Given this list of marker genes G6PC2, AMOTL2, NGFR, ABCD1, NXPH3, CMTR1, CCDC3, HOXC8, KATNAL2, ATG16L1 (NCBI Gene Id 81560), DNMT3B, TTYH3, GIT1, NFASC, RPAP3, LHX6, GATAD2B, CRLF2, INTS6, H2AB1, SPINT3, ERN2, BCL2L1 (NCBI Gene Id 598), NOVA2, ABCC6, LDB3, CYP26B1, MMP24, IGFL3, RSPO4, MYO18A, ELAVL4, BCL7B, IQSEC2, SLC9A1, C5orf15, HCN2, TXK, RIMOC1, C6orf141, MECP2, SEPTIN6 (NCBI Gene Id 23157), TADA3, MPL, CPLX2, SKI, FOXP4, AVPR1A, SYT7 (NCBI Gene Id 9066), TXNRD1, SPATA31D4, PDLIM3, SHISAL1, ADORA3, NSL1, ZSWIM4, SERTAD2, CAPN15, NECTIN1, DTX3, MTHFSD, P2RY4, KCNAB2, IDH3B, LAMC1, PPP2R1A, SLC22A7, PRELP, SEMA4G, MSN, ACSF2, ANKRD13B, BCL7A, URM1, TTC9, CASK, CCDC97, PLEKHM3, CASTOR2, NTSR1, DERL1 (NCBI Gene Id 79139), GARS1, ZC3H7B, STAC2, CNDP1, CENPI, FIBCD1, CBFA2T2, PAX5, BCORL1, SLC6A17, SLC7A8, SEMA6A, NUAK2, GCM1, STX1B, LSAMP, DDA1, PTPDC1, MSI1, MAP3K9, OPA3, VAMP2, TIE1, NFIC, TCF12, ARL5B, ATG14, NACC1, IGF2, here is a description of the gene set: Human Gene Set: MIR4472 Genes predicted to be targets of miRBase v22 microRNA hsa-miR-4472 in miRDB v6.0 with MirTarget v4 prediction scores > 80 (high confidence targets). from publication Chen Y, Wang X (PMID 31504780) studied in species Homo sapiens